Given this list of marker genes SNRPN, PIK3CD, ABCC8, KCNJ11, NARS2, COL11A1, IHH, KNSTRN, here is a description of the gene set: Deviation of the 4th finger Displacement of the 4th finger from its normal position. Human Gene Set: HP_DEVIATION_OF_THE_4TH_FINGER species: Homo sapiens